The following is a description of a gene set: Concentration of carnitine in the blood circulation below the lower limit of normal. Human Gene Set: HP_DECREASED_CIRCULATING_CARNITINE_CONCENTRATION studied in species Homo sapiens Decreased circulating carnitine concentration, and this is the list of marker genes: MCCC2, CPT2, SLC25A20, DLD, TRMU (NCBI Gene Id 55687), HMGCL, HADH, NDUFA2, CTNS, EHHADH, COL7A1, MMP1, ACADVL, SCO1, ACAD8, GATM, ACAD9, MT-TE, ACADM (acyl-CoA dehydrogenase medium chain), SLC34A1, NADK2, SLC22A5, NDUFAF6